Given this list of marker genes PIK3R6, TGM2, ARHGEF1, LCK, NOS3, GNA15, PTGDR, PRKCG, ARR3, GNB5, PRKCB (NCBI Gene Id 5579), PRKCE, HCK, GNA11, VCAM1, RAC1, ARRB2, TBXA2R, ROCK1, EGF, SYK, GNA13, BLK, YES1, GNA12, NHERF1, ICAM1, GNAQ, PTGIR (NCBI Gene Id 5739), RHOA, RAB11A, MAPK14, SRC, PRKCA, PRKCZ, PRKCH, GNG2, GNAI2, MAPK11, PIK3R5, PIK3CG, AKT1, SELE, GRK2, PLCB2, DNM1 (dynamin 1), FYN, GNB1, EGFR, LYN (LYN proto-oncogene, Src family tyrosine kinase), PRKACA, PRKCQ, GRK3, PRKCD, GNA14, FGR, here is a description of the gene set: Thromboxane A2 receptor signaling Human Gene Set: PID_TXA2PATHWAY from publication Schaefer CF, Anthony K, Krupa S, Buchoff J, Day M, Hannay T, Buetow KH (PMID 18832364) species: Homo sapiens